Given this list of marker genes DYNLL1, PTGIS, MIR92A1, MIR199A1, TSPO, SIRPA, ROCK2, GLA, KHSRP, OPRM1, ATP2B4, CAV1, ZC3H12A, ACP5, IL10, here is a description of the gene set: Any process that stops, prevents or reduces the frequency, rate or extent of nitric oxide metabolic process. Human Gene Set: GOBP_NEGATIVE_REGULATION_OF_NITRIC_OXIDE_METABOLIC_PROCESS species: Homo sapiens